Given this list of marker genes MBD2, H3C10, H3-3B, SUV39H1, H3C13, H3C7, RB1, MBD3, RBBP7, HDAC1, H3C2, MTA2, H3C4, RBBP4, E2F1, TP53, H3C8, MTA1, CBX5, CBX1, H3C14, H3C6, LEF1, SREBF1, H3C11, H3C1, MTA3, KDM1A, INPP5K, HDAC2, CHD3, H3-3A, H3C15, CBX3, H3C12, H3C3, CHD4, here is a description of the gene set: Human Gene Set: WP_EFFECT_OF_PROGERIN_ON_GENES_INVOLVED_IN_PROGERIA Effect of progerin on genes involved in progeria species: Homo sapiens